The following is a description of a gene set: electronically inferred by orthology from the curated human pathway studied in species Mus musculus part of: Interferon alpha/beta signaling This event has been computationally inferred from an event that has been demonstrated in another species.<p>The inference is based on the homology mapping from PANTHER. Briefly, reactions for which all involved PhysicalEntities (in input, output and catalyst) have a mapped orthologue/paralogue (for complexes at least 75% of components must have a mapping) are inferred to the other species. Reactome Pathway: Regulation of IFNA/IFNB signaling, and this is the list of marker genes: Ifna9 (NCBI Gene Id 15972), Ifnb1, Ptpn1, Ifnar1, Ifna1, Ifna16, Ifna12 (interferon alpha 12), Tyk2, Ifna4, Ifna15, Ifna14, Ifna13, Ptpn6, Ifnab